The following is a description of a gene set: Mouse Gene Set: MIR_7680_5P Genes predicted to be targets of miRBase v22 microRNA mmu_miR_7680_5p in miRDB v6.0 with MirTarget v4 prediction scores > 80 (high confidence targets). from publication Chen Y, Wang X (PMID 31504780) studied in species Mus musculus, and this is the list of marker genes: Slc30a9, Sp4, Glis3, Armt1, Gmfb, Tmod3, Ndst3, Dlc1, Tmod1, Eri1, Mmp21, Arel1 (NCBI Gene Id 68497), Tent5d, 4930555G01Rik, Cachd1, Ssh2, Arfgef1, Nufip2 (NCBI Gene Id 78671), Nectin1, Smad3, Ppp3cc, Slc7a8, Hao1, Ctnnbip1, Ccdc25, Nuak1, Itm2a, Adgrd1, Gorasp1, Zc3h12c, Hoxa5, Mcidas, Glis1, Flrt3 (NCBI Gene Id 77649), Hdac9, Rgs7, Rab4a, Stx16, Prkx, Zfp516, Ammecr1l, Rev3l, Pak5, Negr1, Nfia, Zfp512b, Cnot6l, Fam135a, Snx27, Slc35d1, Sun1, Tafa2, Nav1, Ppp4r2, Trim44, Myrf, Bnip3, Slc35f5, Lrp2, Sorcs3, Ets1, Mrtfb, Adamts5, Cipc, Zfp958, Usp31, Abhd17c, Fli1, Naa40, AU041133, Tgfbrap1, Vsnl1, Rassf2, Ifit1 (interferon-induced protein with tetratricopeptide repeats 1), Smcp, Ebf1, Aggf1, Zhx2, Rpe, Vasn, Zfp141, Srgap2, Ppp3ca, Pdcd4, Zic2, Serinc5, Bzw1, Ccn1, Abhd17b, Zfp616, Arf6, Caprin1, Arsk, Fzd4, Arhgap21, Tiam1, Gjb2, Pcsk5, Ninl, Kcnn3, Sox9, Pals1, Plxna2, Nedd9, Ntn4, Nap1l1 (NCBI Gene Id 53605), Abr, Sema3a, Hectd1, Zcchc2, Fgf10, Ythdf2, Ccnd2, Slc4a4, Myl12a, Ikzf2, Chchd3, Epb41l5, Phip, Atrnl1, Rasa2, Cacnb2, Camk2d, Ldlrad3, Smad1, Timm23, Naa15, Ebf3, Slc9a6, Vwa8, Klhdc10, Myo5a, Ct55, Erg, Ankrd28, Rab27b, Dmrt3, Heca, Wiz, Bach2, Spop (NCBI Gene Id 20747), Ogt (O-linked N-acetylglucosamine (GlcNAc) transferase (UDP-N-acetylglucosamine:polypeptide-N-acetylglucosaminyl transferase)), Phactr2, Epha7, Ctnnd1, Asap2, Pms1, Cdk6, Hnrnph2, Stim2, Jph1, Mkrn3, Lekr1, Klhl31, Actb, Mfsd2a, Cbfb, Tmem94, Pmp22, Spsb4, Add3, Arhgap15, Nectin3 (nectin cell adhesion molecule 3), Smad5, Adpgk, Tspan6, Cacna1d, Lpar1, Pan2, Retreg2, Ece1, Rcn1, Csn2, Map3k1, Casz1, Kif21a, Elmo1 (NCBI Gene Id 320830), Rps6kb1, Garre1, Gas2, Ano3, Btg1, Dhx15, Scarf1 (NCBI Gene Id 385602), Clvs2 (NCBI Gene Id 215890), Ccdc43, Abracl, Fscn1, Rufy2, Ube2q1, Onecut2, Cntn4, Polr3g, Krtap1-3, Cd28, Ttll7, Clasp2, Arap2, Cdr2l, Stam, Angpt2, Kcna4, Retn, Hipk3, Rnf170, Nudt7, Irs1, Pex2, Fam219a, Dab2, Mbd2, Prdm1, Slc35b3, Tnfrsf11b, Tet2, Mdga2, Rc3h1, Myo6, Mon2, Nphp3, Plxnb3, Zfp704, Plce1, Pcbp4, Adam19, Dusp6, Thumpd3, Tgfbr2, Pex13, Grpel2, Dnase1l1, Camk1d, Trim2, Bcr, Mical3, Ttpa, Slc40a1, Ptpn12, Tmem140, Kifap3, Uba6, Srgap3, Cldn1, Atxn2, Insig1, Paxip1, Mogs, Zfp715, Nol10, Adcyap1, Cdc73 (NCBI Gene Id 96910), Matn2, Dab1, Colq, Vps13b